The following is a description of a gene set: species: Homo sapiens A ubiquitin ligase complex that contains two RING finger proteins, which have ubiquitin ligase activity, in addition to a protein with ubiquitin-conjugating enzyme activity; catalyzes the ubiquitination of histone H2B at lysine 119 (or the equivalent residue). In Schizosaccharomyces the subunits are Rhp6, Shf1, Brl2/Rfp1 and Brl1/Rfp2. Human Gene Set: GOCC_HULC_COMPLEX, and this is the list of marker genes: UBE2A, UBE2B, RNF40, UBE2U, RNF20